The following is a description of a gene set: studied in species Homo sapiens Cross-presentation of soluble exogenous antigens (endosomes) Human Gene Set: REACTOME_CROSS_PRESENTATION_OF_SOLUBLE_EXOGENOUS_ANTIGENS_ENDOSOMES, and this is the list of marker genes: PSMD11, PSMB8, PSMB4, ADRM1, PSMB9, PSMD12, PSMA6, PSMB7, PSMC3, PSMD13, PSMB3, CD207 (NCBI Gene Id 50489), PSMC5, PSMC2, PSMB2, MRC2, PSMC6, PSMA1, PSMA2, PSMD7, PSMB6, PSMD1, PSMD2, PSMA4, PSMC4, FCGR1A, PSMA7, PSMD6, PSMD8, PSMB5, PSMB1, MRC1, PSMA5, FCGR1BP, PSMC1, PSMD14, PSME1, PSMB10, PSMA3, PSMD3, PSME2 (NCBI Gene Id 5721), SEM1